The following is a description of a gene set: Genes predicted to be targets of miRBase v22 microRNA hsa-miR-12126 in miRDB v6.0 with MirTarget v4 prediction scores > 80 (high confidence targets). from publication Chen Y, Wang X (PMID 31504780) Human Gene Set: MIR12126 species: Homo sapiens, and this is the list of marker genes: SAP130, CAMTA1, SLC13A3, KCNJ3, LETMD1, EVI2A, TRPV1, ATP11C, ZDHHC17, ERI1, MTHFD2, RAB1A, RNF180, GOLT1A, PRX, BAG4, ATF7IP2, TMX1, B3GALNT2, PTGDR, KLF4 (NCBI Gene Id 9314), MAPDA, DDX6, AAK1, GSPT1, ARPP21, TOR1AIP1, CMTM8, PDPN (NCBI Gene Id 29912), FGA, HMGN3, BCL9, NRXN1, OLIG3, DIO2, MTPN